Given this list of marker genes Mcf2l, Ednra, Ccl7, Plod2, Arhgap18, Serpinb1a, here is a description of the gene set: Stimulation of osteoblast differentiation from mesenchymal stem cells is a potential strategy for bone repair. Bone morphogenetic proteins (BMPs) that induce osteoblastic differentiation have been successfully used in humans to treat fractures. Here we outline a new approach to the stimulation of osteoblast differentiation using small molecules that stimulate BMP activity. We have identified the amiloride derivative phenamil as a stimulator of osteoblast differentiation and mineralization. Remarkably, phenamil acts cooperatively with BMPs to induce the expression of BMP target genes, osteogenic markers, and matrix mineralization in both mesenchymal stem cell lines and calvarial organ cultures. Transcriptional profiling of cells treated with phenamil led to the identification of tribbles homolog 3 (Trb3) as a mediator of its effects. Trb3 is induced by phenamil selectively in cells with osteoblastic potential. Both Trb3 and phenamil stabilize the expression of SMAD, the critical transcription factor in BMP signaling, by promoting the degradation of SMAD ubiquitin regulatory factor 1. Small interfering RNA-mediated knockdown of Trb3 blunts the effects of phenamil on BMP signaling and osteogenesis. Thus, phenamil induces osteogenic differentiation, at least in part, through Trb3-dependent promotion of BMP action. The synergistic use of small molecules such as phenamil along with BMPs may provide new strategies for the promotion of bone healing. from publication Park KW, Waki H, Kim WK, Davies BS, Young SG, Parhami F, Tontonoz P (PMID 19433444) Genes down-regulated in M2-10B4 cells (osteoblast) in response to phenylamil. studied in species Mus musculus Mouse Gene Set: PARK_OSTEOBLAST_DIFFERENTIATION_BY_PHENYLAMIL_DN